Given this list of marker genes PRKACA, PPP3CB, AKAP5, PRKACB, ROBO3, PRKAR2A, PRKACG, ROBO2, PRKCA, here is a description of the gene set: studied in species Homo sapiens Reactome Pathway: ROBO receptors bind AKAP5 AKAP5 (also known as AKAP79 in humans and Akap150 in mice) is an A-kinase anchoring protein which is able to bind to ROBO receptors ROBO2 and ROBO3.1, an isoform of ROBO3, by interacting with their cytoplasmic tails. The interaction was originally detected between endogenous proteins from the mouse brain lysates. AKAP5 can recruit protein kinase A (PKA), protein kinase C (PKC) and protein phosphatase PP2B to ROBO2. AKAP5-mediated recruitment of PKC to ROBO3.1 leads to phosphorylation of ROBO3.1 by PKC. Functional implications of AKAP5 interaction with ROBO receptors are not known. part of: Signaling by ROBO receptors